Given this list of marker genes DPF2, DNMT3A, CWC27, ERF, HRAS, NFKB2, PPP1CB, KMT2D, NONO, H3-3A, ZEB2, NOTCH3, CREBBP, SLC30A7, MLXIPL, NOVA2, KCNH5, STAG1, POLR3B, SETBP1, SH2B1, KANSL1 (KAT8 regulatory NSL complex subunit 1), PLAAT3, DHCR7, POLR3A, SMO, CSF1R, DHDDS, KDM6A, PEX11B, MAF, SPRED1, STAT3, TMEM94, NFIA, KRAS, ELN, SLC39A14, PAX2, TRPM3, SKI, PIEZO2, DKK1, EP300, SETD2, PHEX, CDC45, TAOK1, FGFR2, RAD51, here is a description of the gene set: Chiari type I malformation Arnold-Chiari type I malformation refers to a relatively mild degree of herniation of the posteroinferior region of the cerebellum (the cerebellar tonsils) into the cervical canal with little or no displacement of the fourth ventricle. It is characterized by one or both pointed (not rounded) cerebellar tonsils that project 5 mm below the foramen magnum, measured by a line drawn from the basion to the opisthion (McRae Line) species: Homo sapiens Human Gene Set: HP_CHIARI_TYPE_I_MALFORMATION